The following is a description of a gene set: Mouse Gene Set: MEISSNER_NPC_HCP_WITH_H3K4ME3_AND_H3K27ME3 DNA methylation is essential for normal development and has been implicated in many pathologies including cancer. Our knowledge about the genome-wide distribution of DNA methylation, how it changes during cellular differentiation and how it relates to histone methylation and other chromatin modifications in mammals remains limited. Here we report the generation and analysis of genome-scale DNA methylation profiles at nucleotide resolution in mammalian cells. Using high-throughput reduced representation bisulphite sequencing and single-molecule-based sequencing, we generated DNA methylation maps covering most CpG islands, and a representative sampling of conserved non-coding elements, transposons and other genomic features, for mouse embryonic stem cells, embryonic-stem-cell-derived and primary neural cells, and eight other primary tissues. Several key findings emerge from the data. First, DNA methylation patterns are better correlated with histone methylation patterns than with the underlying genome sequence context. Second, methylation of CpGs are dynamic epigenetic marks that undergo extensive changes during cellular differentiation, particularly in regulatory regions outside of core promoters. Third, analysis of embryonic-stem-cell-derived and primary cells reveals that 'weak' CpG islands associated with a specific set of developmentally regulated genes undergo aberrant hypermethylation during extended proliferation in vitro, in a pattern reminiscent of that reported in some primary tumours. More generally, the results establish reduced representation bisulphite sequencing as a powerful technology for epigenetic profiling of cell populations relevant to developmental biology, cancer and regenerative medicine. from publication Meissner A, Mikkelsen TS, Gu H, Wernig M, Hanna J, Sivachenko A, Zhang X, Bernstein BE, Nusbaum C, Jaffe DB, Gnirke A, Jaenisch R, Lander ES (PMID 18600261) Genes with high-CpG-density promoters (HCP) bearing histone H3 trimethylation marks at k4 (H3K4me3) and K27 ((H3K27me3) in neural precursor cells (NPC). studied in species Mus musculus, and this is the list of marker genes: Adra2b, Mnx1 (NCBI Gene Id 15285), Gpat3, Fgf11, Ccdc85a (NCBI Gene Id 353081), Kcnj4, Gpc5, Ccno, Coch, Kif5c, B4galnt3, Kndc1, Pde4a, Ina, Fgf9, Eomes, Unc5a, Ablim2, Megf11, Sfi1, D430041D05Rik, Epha2, Gpr45, Pltp, Klhdc8a, Gad1, Ptpru, Gdf6, Ankrd33b, Slc35d3, Adra2a, Esrrb, Atoh8 (NCBI Gene Id 71093), Erbb3 (erb-b2 receptor tyrosine kinase 3), Igf2bp2, Rassf5, Rasgef1b, Gch1, Plekhg3, Fgf5, Bmf, Col27a1, Chst8, Wnt11, Tub, Nppc, Ndrg1 (N-myc downstream regulated gene 1), Disp3, P2ry2, Elfn1, Tenm4, Tead4, Tuba4a, Emb, Gnal, Cdkn1a, Efcc1, Bhlhe22, Tmtc4, Egr4, Arg2, Cdh22, Adamts8, Atoh1, Nmnat2, Kif26b, Sh3rf3, Flt1, Plxna4, Rnf152, Kcnh3, Arhgap44, Kank4, Satb1 (NCBI Gene Id 70334), Khdrbs2, Elmod1, Cldn23, Vstm2b, Nxph4, St8sia2, Foxo6, Fgf15, Neurog2, Jph1, Cwc22, Dll4, Ptpn5 (NCBI Gene Id 19259), Inf2, Tspan18, Cds1, Neurog1, Rgs9bp, Kcnma1, Galnt3, Adora1, Wdr20 (WD repeat domain 20), Vgf, Reln, Epha10, Camkk1, Rspo2, Csmd1, Wnk2, Lmo2, Smad6, Adora2b (NCBI Gene Id 632506), Slc24a4, Mapk8ip2, Fbxo43 (NCBI Gene Id 78803), Cbln1, Pitx2, Ak5, Hcn4, Rab15, Cxcl12, Rab20, Foxb1, Plag1, Slc24a2, Gprc5c, Fhl2, Epb41l1, Myo1d, Chrna5, Ica1l, Stk32c, Hoxc4, Map3k9, Etnk2, Celsr3, Synm, Atp7b, Slc35f2, Pcdh8, Nefl, Nefm, Frmd5, Nrarp, Sox1, Grm8, Grem1, Ntng1, Gpr88